Given this list of marker genes DHCR24, SPTBN1, COL4A5, TERT, ELMO2, RSPRY1, GJC2, RPL31, IFNG, ANAPC1, SUFU, MEN1, RPL9, PLA2G2A, RPL8, EPHB4, PDE11A, RPS10, HRAS, EP300, COL4A6, SDHB, SDHA, RPL27, PTCH1, AXIN2, BAX, RPL35A, PLCD1, IDH2, KRT17, CDKN1A, FAS, EPCAM, ADA2, MAD1L1, CDKN2A, MCC, SOS1, EWSR1, CDC73, TRIP13 (thyroid hormone receptor interactor 13), SDHC, MTAP, MSH6, SDHD, RPS26 (NCBI Gene Id 6231), RPS17, PIEZO1, FGFR3, PDGFB, PTEN, CCND1, AURKA, PDGFRA, IL6ST, TAF15, HEATR3, FAM20C, BUB1B, PDGFRB, FASLG, RAD54B, TGFBR2, NBN, RPS15A, BUB1, RPS20, TP53, USF3 (NCBI Gene Id 205717), MLH3, TLR2, PMS1, PTPN11, CEP57, PDGFRL, FH, EXT2, PAX3, NUTM1, KLLN, RPS27, MLH1, WT1, SRC, SEC23B, PMS2, FOXO1, ABCA5, MAP2K1 (mitogen-activated protein kinase kinase 1), NF2, PIK3CA, RPS19, CHEK2, PRKAR1A, FLCN, ASPSCR1, RPS7, FAM20A, PTCH2, TRAF7, AKT1, TSC1 (NCBI Gene Id 7248), WRN, GDF5 (NCBI Gene Id 8200), PTH1R, RECQL4, RPL26, BRD4, EXT1, KEAP1, SPRED1, BAP1, CTNNB1, DCC, SMARCB1, GNAS, RPL35, REST, RPS28, DICER1, PAX7, FLT4 (fms related receptor tyrosine kinase 4), ANGPT2, BUB3, IDH1, SLC22A18, CDKN2B, SQSTM1, FLNA, SMARCE1, PTPRJ, RPL11, DLC1, RPS29, ANTXR2 (NCBI Gene Id 118429), RPL5, NF1, LRP1, CDKN1B, RPS24 (NCBI Gene Id 6229), PTPN12, BMPR1B, APC, ATP6V1B2, CASP10, GATA1, NRAS, RB1, SMO (NCBI Gene Id 6608), LMNA, KCNH1, BRAF, TSC2, NR4A3, NOTCH3, RPL18, TSR2, RPL15, FOXC2, MSH2, COL1A1, KCNN3, KRAS, CDKN2C, KIT, MDM2, PRLR, here is a description of the gene set: Sarcoma Human Gene Set: HP_SARCOMA species: Homo sapiens A connective tissue neoplasm formed by proliferation of mesodermal cells. Bone and soft tissue sarcomas are the main types of sarcoma. Sarcoma is usually highly malignant.